The following is a description of a gene set: T cell receptor engagement in the absence of proper accessory signals leads to T cell anergy. E3 ligases are involved in maintaining the anergic state. However, the specific molecules responsible for the induction of anergy have yet to be elucidated. Using microarray analysis we have identified here early growth response gene 2 (Egr-2) and Egr-3 as key negative regulators of T cell activation. Overexpression of Egr2 and Egr3 was associated with an increase in the E3 ubiquitin ligase Cbl-b and inhibition of T cell activation. Conversely, T cells from Egr3(-/-) mice had lower expression of Cbl-b and were resistant to in vivo peptide-induced tolerance. These data support the idea that Egr-2 and Egr-3 are involved in promoting a T cell receptor-induced negative regulatory genetic program. Genes up-regulated in anergic mouse T helper cells (A.E7), versus non-anergic stimulated controls from publication Safford M, Collins S, Lutz MA, Allen A, Huang CT, Kowalski J, Blackford A, Horton MR, Drake C, Schwartz RH, Powell JD (PMID 15834410) Mouse Gene Set: SAFFORD_T_LYMPHOCYTE_ANERGY studied in species Mus musculus, and this is the list of marker genes: Clec4e, Tnfrsf19, Anp32a (acidic nuclear phosphoprotein 32 family member A), Kcnk5, Gadd45b (growth arrest and DNA-damage-inducible 45 beta), Hsd17b6, Ankrd28, Etv6, Nr4a2, Slc29a3, Hspa1a, Pla2g10, S100a5, Srgn, Ing4, Gga2, Tnfrsf4, Gch1, Angptl2, Jup, Lpar4, Dusp6, Foxp1, Cd40lg, Oaz3, Rcbtb1, Irf4, Kif15, Isyna1, Noct, Kifc3, Egr2, Mpzl2, Myo1c, Ndrg1, Adgre5, Casp4, Kcnj11, Gabra4, Zfp36l1, Zfp629, Lrrc3, Dtna, Rnf19a, Csf1, Ctse, Ccl1, Ddr1, Ccl3, Hif1an, Furin, Dlg2, F2r, Pfkp, Cdc14a, Adora2a, Nr4a3, Notch1, Ier3, Marchf2, Adora2b, Fbxo34, Lilrb4a, Tnfsf9, Sfrp4, Hspa4l, Arfip1, Actn4, Fyn, Bnip3, Agt, Jak3, Nfatc1, Jarid2, Kcnq5, Myl7, Tnfsf11, Lag3, Myh14, Mill1, Stx11, Tinag, Hebp2, Tekt2, Myo1e, Socs4, Mmd, Hlf, Trp53rkb, Tagap1